The following is a description of a gene set: A fine reticular network of membrane-limited elements that pervades the sarcoplasm of a muscle cell; continuous over large portions of the cell and with the nuclear envelope; that part of the endoplasmic reticulum specialized for calcium release, uptake and storage. Human Gene Set: GOCC_SARCOPLASMIC_RETICULUM studied in species Homo sapiens, and this is the list of marker genes: HAX1, MANF, ATP2A2, JPH2, DMPK, HK2, SLN, SYNE2, IRAG1, TMEM38B, GSTM2, POMT1, AKAP6, CAMK2D, FSD2, H6PD, SRL, FKBP1A, ITPR3, P3H2, HSP90B1, DHRS7C, RYR1, RTN2 (NCBI Gene Id 6253), SLC30A7, NOS1AP, CAMK2G, CMYA5, CALR, STIM1, ITPR2, TMEM109, ART1, JPH3, RASD1, RYR3 (NCBI Gene Id 6263), AGL, TRDN, SRI, THBS1, SGCD, ANK1, MTMR12, ATP2A3, S100A1, KLHL41, JPH1, RYR2, OPRK1, NOL3, FKBP1B, ITPR1, CLEC18B, CAMK2B, XDH, CALU, THBS4, ATP2A1, COL6A1, NOS1, FKBP1C, JSRP1, HRC, REEP5, ASPH, CASQ1 (calsequestrin 1), MRLN, JPH4, CACNA2D1, TMEM38A (NCBI Gene Id 79041), PLN, CASQ2, STRIT1, CACNA1S, CHERP, ANK3, CCDC78, SLC2A4